Given this list of marker genes SPCS3, P, SEC11A (SEC11 homolog A, signal peptidase complex subunit), M, N, KPNB1, SH, M2-1, PPP1CC, CSNK2B, G, 1C, XPO1, FURIN, CSNK2A1, L, SEC11C, PPP1CA, F, CSNK2A2 (NCBI Gene Id 650690), PPP1CB, 1B, SPCS2, SPCS1, here is a description of the gene set: species: Homo sapiens Human respiratory syncytial virus contains genes which are translated into 11 proteins, of which 2 have translation isoforms due to use of alternative translation initiation codons. These proteins function in viral replication and host interaction. Fusion protein F, glycoprotein G, and both variants of small hydrophobic protein, SH and SHt, get glycosylated and F, G, and SH later migrate to the plasma membrane where virion assembly takes place. Matrix protein M first translocates to the nucleus and back to cytosol before serving as a scaffold at the assembly site. M2-1 is also found in the nucleus. Phosphorylations, partially transient, appear to be necessary for oligomerization and function of the SH, N, P, M, and M2-1 proteins (Gan & Torres, 2011; McLellan et al, 2013; Muniyandi et al, 2018; Anderson et al, 2021). part of: Respiratory syncytial virus (RSV) genome replication, transcription and translation Reactome Pathway: Maturation of hRSV A proteins